The following is a description of a gene set: Mouse Gene Set: MIR_770_5P species: Mus musculus from publication Chen Y, Wang X (PMID 31504780) Genes predicted to be targets of miRBase v22 microRNA mmu_miR_770_5p in miRDB v6.0 with MirTarget v4 prediction scores > 80 (high confidence targets)., and this is the list of marker genes: Peg10, Tlcd4, Purg, Nap1l5, Golga1, Gpx7, Ctnnb1, Col24a1, Tmem87a, Hoxd10, Lpl (lipoprotein lipase), Usp42, Smad6, Tmtc3, Fem1b, Cul5, Plekhf2, Ints15, Rims2, Adam17 (a disintegrin and metallopeptidase domain 17), Cop1 (COP1, E3 ubiquitin ligase), Trhde, Syt16, Narf, Zdhhc3, Manbal, Foxk2, Mga, Rab6b, Tyw1, Sgk1, Dazap2, Zmym4, Cisd1, Supt16, Cinp, Ctr9, Ikbkg, Zfhx4, Phtf2, Drp2 (dystrophin related protein 2), Eml5, Csde1, Fbxw7, Acvr2b, Slc23a4, Mocs2, Tshr, Ppic, Sertad2, Zfp28, Rnf215, Fnip2, Nxn, Mapk1, Tet1, Ark2c, Scn1a, Krt71, Neu1, Zfp346, Plxnc1, Nhsl2, Fras1, Hycc2, Col5a1, Ccnyl1 (cyclin Y-like 1), Ccdc117, Osbpl11, Cenpt, Zdhhc11, Rap1b, Slc9a6, Hecw1